The following is a description of a gene set: Mouse Gene Set: GOBP_BONE_MATURATION species: Mus musculus A developmental process, independent of morphogenetic (shape) change, that is required for bone to attain its fully functional state., and this is the list of marker genes: Adamts7, Sema4d, Plxnb1, Grem1, Ccdc154, Ltf, Phospho1, Ebp, Rhoa, Ryr1, Mbtps2, Lep, Ift80, Zbtb16, Pth, Fgfr3, Rflna, Asxl2, Bmp2, Rflnb, Actn3, Ext1, Igf1, Fat4, Enpp1, Thbs3 (thrombospondin 3), Dchs1, Xylt1, Ano6, Adamts12, Snx10